The following is a description of a gene set: T cell modulation and desmoplasia in pancreatic cancer species: Homo sapiens Human Gene Set: WP_T_CELL_MODULATION_AND_DESMOPLASIA_IN_PANCREATIC_CANCER, and this is the list of marker genes: CTLA4, B2M, VDR (vitamin D receptor), CXCL12, CD276, HLA-A, IL4, VEGFD, NT5E, TIGIT, IL13, CD86, TNFSF9, ICOS, CXCR4, CCL22, TGFB2, LGALS3, CD40LG, CCL17, CD28, TGFB1, TGFB3, CD274, LGALS9, PDGFB, VEGFC, FASLG, PGF, LGALS1, FAS, PVR (PVR cell adhesion molecule), ARG1, CD40, CD226, PDCD1, PDCD1LG2, IL6, PDGFD, SHH, ENTPD1, FAP, PDGFA, VEGFB, PDGFC, TNFRSF4, TNFRSF9, HAVCR2, VEGFA, TNFSF4, VSIR, VTCN1, CD80, IDO1, IL10